The following is a description of a gene set: studied in species Homo sapiens Recurrent patellar dislocation Patellar dislocation occurring repeated times. Human Gene Set: HP_RECURRENT_PATELLAR_DISLOCATION, and this is the list of marker genes: PRKACB, PIEZO2, RYR1, MAB21L2, BPNT2, AHDC1, AEBP1, SCARF2 (scavenger receptor class F member 2)